Given this list of marker genes MAP2K1, PRKAG3, NR1H3, RPTOR, EXOC7, MAP3K1, FLOT2, MAP4K1, PIK3CB, MAPK14, MAP2K3, MAPK1, THRB, RAF1, RPS6KB1, FBP1, MAP3K2, FOXO3, CYP7A1, ABCG8, MAP3K9 (NCBI Gene Id 4293), MLST8, THRA, RAPGEF1, MAP3K4, CBLB, MAPK12, CBLC, PIK3C2G, CBL, MAPK9, MAP3K3, G6PC1, SLC16A2, MAP3K13, PIK3CD, MAP3K7, SCD, RPS6KA3, MAP2K4, MAP3K10, FASN, TSC2, IRS1, SOS1, EIF4EBP1, PCK1, RPS6KB2, SESN3 (NCBI Gene Id 143686), MAPK8, GYS1, RPS6KA4, MAP2K7, CYP2B6 (cytochrome P450 family 2 subfamily B member 6), MAPK13, SLC2A4, FLOT1, PRKAB2, MAPK3, MAPK11, PIK3R2, CYP3A4, RPS6KA2, PIK3R3, PDPK1, MAPKAP1, PIK3R1, SLCO1C1, MAP2K6, PIK3CG, RPS6KA5, PTPN1, HRAS, MAP3K11, PRKAG2, GSK3A, AKT2, MAP3K5, PIK3R4, SLC2A1 (NCBI Gene Id 6513), MAP3K6, RXRA, MAPK7, PRKAG1, INSR, RPS6KA6, MAP3K12, INS, MAPK4, SOS2, SHC3, SHC2 (SHC adaptor protein 2), RICTOR, PRKAA1, MAPK6, RHOQ, RHEB, SREBF1, MAP4K4, PRKAB1, MAP2K2, IRS4, MAP2K5, SHC1, PIK3CA, MAP3K14, MAP4K3, MAPK10, MTOR, RPS6KA1, ANGPTL8, PIK3C3, MAP4K2, EIF4E, MAP3K8, MAP4K5, GSK3B, LPL, MINK1, TSC1, FOXO1, DIO2, ABCG5, SREBF2, AKT1, PRKAA2, IRS2, TRIP10, PIK3C2A, CAP1, CRK, MLXIPL, here is a description of the gene set: Angiopoietin-like protein 8 regulatory pathway species: Homo sapiens Human Gene Set: WP_ANGIOPOIETINLIKE_PROTEIN_8_REGULATORY_PATHWAY